The following is a description of a gene set: Human Gene Set: GOBP_POSITIVE_REGULATION_OF_ATTACHMENT_OF_MITOTIC_SPINDLE_MICROTUBULES_TO_KINETOCHORE species: Homo sapiens Any process that activates or increases the frequency, rate or extent of attachment of spindle microtubules to kinetochore involved in mitotic sister chromatid segregation., and this is the list of marker genes: CDCA8, BIRC5, INCENP, BECN1, KAT5, KAT2B, HNRNPU, AURKB